The following is a description of a gene set: Human Gene Set: GSE36476_CTRL_VS_TSST_ACT_40H_MEMORY_CD4_TCELL_YOUNG_DN With increasing age, the ability of the immune system to protect against recurring infections or to control chronic infections erodes. The objective of the current study was to identify gene expression signatures in elderly CD4 T cell responses Genes down-regulated in comparison of untreated CD4 memory T cells from young donors versus those treated with TSST at 40 h. from publication Yu M, Li G, Lee WW, Yuan M, Cui D, Weyand CM, Goronzy JJ (PMID 22434910) species: Homo sapiens, and this is the list of marker genes: TJP2, UCK2, TUBB, SAC3D1, CALML4, PTPN7, RAD51D, MCUR1, NCAPG, CCNB1, CCNB2, GINS3, PPCDC, NCAPH, MCM2, TYMS, CDC25C, IFI30, HPRT1, IL12RB2, JPT2, TARS1, LAMP3, HILPDA, TALDO1, IPO5 (importin 5), EXOSC4, WDR77, SLC25A5 (NCBI Gene Id 292), RACGAP1, PFAS, HMBS, METTL13, TPX2, KIF11, RPA3, IL1R2 (interleukin 1 receptor type 2), BRCA1, POLA1, CLIC2, KIF20A, MCM4, NCAPG2, TPI1, FANCG, IL2RA, RBBP8 (RB binding protein 8, endonuclease), GBA1LP, UBE2C, SLC6A12, IRF4, SHMT1, CCNE2, NME1, HMMR, DTL, CKS2, ASPM, TMEM140, SLC39A14, CDCA3, FEN1, PCNA, TTI2, CD200, IL1R1, SKA1, CENPE (centromere protein E), ACOT7, TXLNA, TUBA1C, SORD, CENPM, VDAC3, TYMP, TIMM13 (NCBI Gene Id 26518), PAICS, BRCA2, CCL17, CCDC51, ACTG1, PXMP2, TOP2A, UQCC1, FAH, VDR, CHAF1A (chromatin assembly factor 1 subunit A), AIM2, CENPU, CDC45, CENPS, RFC4, NUSAP1, ALAS1, CKAP5, STT3A (STT3 oligosaccharyltransferase complex catalytic subunit A), PXMP4, DNAJB6, SPAG5, TUBB6 (tubulin beta 6 class V), DTYMK, CENPA (NCBI Gene Id 1058), CTPS1, INSM1, KIF18B, PCLAF, FABP5, MYOF, LIG3, STIP1, CDKN3, LIG1, SLCO4A1, SRPK1, RAD54L, TUBG1, CISD1, ZBED2, GRK3 (NCBI Gene Id 157, G protein-coupled receptor kinase 3), RAB38, MYL6B, CSNK2B, AIMP2, GMPPB, PALB2, CTNNA1, MCM7, AFG2B, ABCG2, PRDX4, RAD51, DUT, DHCR24, IMMT, CKS1B, TK1, PUS7, RRM2, RBM4B, MRPL35, CDC20, UBL4A, MCM10 (minichromosome maintenance 10 replication initiation factor), SMC1A, TUBA1B, CCL22, BATF3, TP53BP1, LGMN, CDCA8, SLC43A3, MKI67, BIRC5, FIBP, THOC6, STMN1, CEP15, ALDH2, KIF2C, BYSL, PGAM1, ACY1, TMEM106C, DHFR, FANCA, CEP55, KCNK5, YWHAH, KIF23, TRIP13, ZNF282, POLE2, NQO1, BLM, ESPL1, SRSF1, LMNB2, AURKB, MRPL20, ZWILCH, DCTPP1, CDK2AP1, TXN, KIF4A, SPRED2, CTLA4, PCK2, UMPS, MCM5, CCNE1, VANGL1, HJURP, FH, GINS2, WARS1, MRPS18B, GCNT1, BATF, POLA2, GALE